Given this list of marker genes Cnpy1, Spred3, Dmbx1, Impdh2, Wnt1 (wingless-type MMTV integration site family, member 1), Fgf17, Fgf15, B130046B21Rik, Egfem1 (EGF-like and EMI domain containing 1), Efna5, Wfikkn1, Mrpl16, En2, Gm26608, Gm15637, Spry1, Trh, Pwwp3a, Wfdc1, here is a description of the gene set: studied in species Mus musculus Mouse Organogenesis Cell Atlas (MOCA) DE_gene_main_cluster.csv, fold.change>=1.5, qval<0.05, pval<0.05 from publication Cao J, Spielmann M, Qiu X, Huang X, Ibrahim DM, Hill AJ, Zhang F, Mundlos S, Christiansen L, Steemers FJ, Trapnell C, Shendure J (PMID 30787437) Mouse Gene Set: DESCARTES_ORGANOGENESIS_ISTHMIC_ORGANIZER_CELLS